Given this list of marker genes Atg5, Rnf19a, Drd2, Eif4e, Trio, Igf1r, Eif4a3, Nrgn, Ghsr, Ina, Iqsec1, Cdh1, Grm3, Usp8, Plcb1, Mdm2, Ppp3r1, Camk4, Cyfip1, Slc1a1, Nefh, Tent2, Synpo, Rasgrf2, Clmp, Dcc, Prkaca, Ghrl, Ptk2b (PTK2 protein tyrosine kinase 2 beta), Fbxo2, Eif4a3l2, Fmr1, Sorcs3, Ppp3ca, Nedd4, Ngdn, Snx14, Wnt5a, Braf (Braf transforming gene), Chrm1, Nefl, Drd1, Eif4a3l1 (eukaryotic translation initiation factor 4A3 like 1), Igf1, Gnao1, here is a description of the gene set: studied in species Mus musculus Mouse Gene Set: GOBP_POSTSYNAPTIC_MODULATION_OF_CHEMICAL_SYNAPTIC_TRANSMISSION Any process, acting in the postsynapse that results in modulation of chemical synaptic transmission.